Given this list of marker genes Smcr8, Lypd10, Fmr1, Nppc, Pla2g3, Cadps2, Stx1b, Doc2b, Syt4, Rab7, Exoc2, Stxbp5, Itgb2l, Gnai2, Syt1, Il13ra2, Septin4, Htr1d, Cbarp, Hap1, Vamp2, Cdk5r2, Notch1, Pld2, Stxbp2, Cask, Tpcn2, Myo5b, Fbxl20, Trim9, Cd300a, Cplx1, S100a10, Myo5a, Wnt7a, Wdr41, Baiap3, Sv2b, Cacna1d (NCBI Gene Id 97919), Cd160, Arf1, Stxbp3, Sdc1, Stx4a, Rab27a, Rala, Lgi3, Prkcg, Cacna1h, Rapgef4, Fbxo45, Epb41l1, Atp2a2, Stxbp5l, Anxa1, Syt8 (synaptotagmin VIII), Lyn, Ppfia2, Prkcb, Prkn, Il1rapl1, Gab2, Nlgn1, Rest, Pdpk1, F2rl1, Syt6, Bcl2l1, Gata1, P2ry4, Rab33b, Scamp5, Pdcd6ip, Il4ra, Ceacam1, Snap23, Vps18, Dtnbp1, Atp13a2, Stxbp1, Rab5a, Prkca, Anxa2, Ptafr, Nsf, Cadps, Rab3gap1, Snf8, Syk, Rab37, Snx4, Adora3, Fcer1g, Tcp11, Rph3a, Fes, Il13, Kcnh1, Braf, Hgs, Cacna1e, Septin5, Lamp1, Gpr151 (NCBI Gene Id 240239), Rab21, Sytl4, Cplane2, Rab26, Kcnb1, Tprg1l, Rufy4, Syt11, Pla2g6, Cacna1g, Cftr, Cacna1a, Rab3d, Vps4b, Fga, P2rx2, Rims3, Lrrk2, Hyal3, Rab3b, Rab2b, Cspg5, Dvl1, Zp3, Septin1 (NCBI Gene Id 54204), Snapin, Syt9, Bcr, Doc2g, Slc4a8, Syt3, Fgb (fibrinogen beta chain), Spi1, Nppa, Rab9, Rims4, Pram1, Rac2, Vsnl1, P2ry1, Itgb2, Cdk5, Sv2c, Adra2a, Rab15, Tsg101, Mical1, Syt12, Fgr, Ms4a2, Unc13b, Vamp8, Snap29, Ccr2, D6Wsu163e, Clasp2, Chmp2a, Dnm1l, Clasp1, Pclo, Exph5, Syt13, Cacna1i, Abr, Sdc4, Npy1r, Rims1, Sphk2, Sdcbp, C9orf72, Git2, Rab3c, Rap1a, Hmox1, Htr1b, Smpd3, Lgals9, Pfn2, P2rx1, P2ry2, Fcer1a, Crhr1, Rabgef1, Syt5, Npy, Syt7, Syt15, Rims2, Snca, Cd177, Syt10, Adora2b, Ap1g1, Pou5f1, Git1, Rab3a, Stx1a, Rab27b, Foxf1, Syt17, Nckap1l, Vps4a, Prepl, Rap1b, Cacnb4, Lypd11, Il4, Cd84, Fgg, Syt2, Rph3al (NCBI Gene Id 76242), Doc2a, Atp9a, P2rx7, Ncs1, Gata2, Unc13d, Itgam, Syn1 (NCBI Gene Id 20964), Stam (signal transducing adaptor molecule (SH3 domain and ITAM motif) 1), here is a description of the gene set: studied in species Mus musculus Any process that modulates the frequency, rate or extent of exocytosis. Mouse Gene Set: GOBP_REGULATION_OF_EXOCYTOSIS